The following is a description of a gene set: from publication Martinez FO, Gordon S, Locati M, Mantovani A (PMID 17082649) Human Gene Set: GSE5099_MONOCYTE_VS_ALTERNATIVE_M2_MACROPHAGE_DN Monocytes mature tom acrophages in the presence of the lineage determining cytokine M-CSF. They can be further polarized into M1 or M2 macrophages with distinct functional properties. We used microarrays to detail the global programme of gene expression underlying macrophage maturation and polarization and identified distinct classes of up-regulated genes during this process. studied in species Homo sapiens Genes down-regulated in monocytes versus alternatively activated (M2) macrophages., and this is the list of marker genes: TMC7, ABCC12, OR51B5, NPTN, POU2F3, NFIX, ARHGAP45, NAT16, DNAJB2, CNOT1, C19orf12, BTBD8, P4HA1, RAB24, DNAJC21, SYNJ1, VEGFA, CPT1A, POMGNT2, ATP5F1E, MALT1, PAK2, ARMC10, DNAJB4, YME1L1, SNX27, MAT2B, PER1, SERP1, ZBTB18, TULP4, LRCH1, GALNT9, RAET1E, ARL5A, ZNF137P, DYNLL1, CEP104 (centrosomal protein 104), GRK6, ESRP2, C5orf58, PNRC2, ZNF277, SAFB, EGLN1, TMA7, KLHL9, STYXL1, ZNF493, ACAP3, GIMAP2, ATP6V1G2, LINC00895, CCNA2, APOL2, OR7D2, TRRAP, C1D, PAH, NIN, ANKRD37, CDK5R1, SMURF2 (NCBI Gene Id 64750), TEDC2-AS1, ZNF425, GREM2, DCP2, RASL11A, MIR622, SMIM30, LYRM2, CORT, OPA3, CTSZ, SIX6, PPIL4, DSN1, CACNG6, TPM3, UBE2L6, ZNF589, CNTNAP1, KPNA4, FAM168A, HSPA5, ZNFX1, CASP9, IDUA, HCRTR2, ZNF439, GEMIN5, LAT2, EIF4G2, R3HDM2, KCNV1, CLPTM1L, HISLA, STXBP3, COPS5, GNG13, HEXD, GOLPH3, OSBPL8, SUCLA2, GMDS, B3GAT1, WDR33, CRKL, RIMS4, ATP2A2, ZNF738, PLS3, COPS9, ZNF638, BET1, CLN3, TAS2R1, SLC26A6, EGFL6, LRRC1, EYA3, SYN2, NUP43 (NCBI Gene Id 79700), NPSR1-AS1, PLEKHS1, CMYA5, CARINH, CRTC3, CELF5, TET3, COMMD7, LINC00607 (long intergenic non-protein coding RNA 607), CHMP5, PARP8, STRAP, UBR1, ATP6V1C2, TMEFF1, ZDHHC20, PHAX, OR2B6, HNRNPA2B1, ICA1, MKNK1-AS1, POU1F1, TFF3, PAIP1, METTL15 (methyltransferase 15, mitochondrial 12S rRNA N4-cytidine), EVI2B, MAGI3, PPP1R3C, HEMK1, IMMP1L, TRANK1, HIBCH (NCBI Gene Id 26275), TAF3, STON2, CYBC1, GTF3C3, AGO2, RNF213, CKAP2, ZNF264, ZNF708, C4orf17, MCUB, SIRT3, UBE2CP4, RAB6A (RAB6A, member RAS oncogene family), ZNF526, GOLM2, CCDC88B, LPAR1 (NCBI Gene Id 1902), NCKIPSD, RNF20, FKBP14, GPHN, RUFY1, HNRNPC, SSBP3, INPP4A, SMAP2, PRR22, FSD2, SEC24A, TUBE1, METRN, PHF8, FAR1, GTF2A2